Given this list of marker genes Cers3, Elovl1, Vapa, Fa2h, Acer2, Elovl2, Zfp750, Cerkl, Paqr4, Ormdl3, Hacd2 (NCBI Gene Id 70757), St6galnac3, St6galnac4, Elovl4, St8sia3, Abca2, Sgms1, Tm9sf2, St3gal2, St3gal1, Agk, P2rx1, Degs1l, Degs2, B4galnt1, Osbp, Samd8, Alox12b, Ugt8a, St8sia6, Tlcd3b, Hacd3, Acer3, Gzmb, B3galt4, Hacd1, B3galt1, Asah2, B4galt3, Fut9, Sptlc2, Cers4, Kdsr, St3gal3, Sphk2, St8sia2, Elovl7, Smpd4, St6galnac6, Sptlc1, Cers5, St8sia5, Pemt, Fut4, Pnpla1, Sgms2, P2rx7, Casp1, Elovl3, A3galt2, Cers1, B3galt2, Sirt3, Cers6, Mecr (mitochondrial trans-2-enoyl-CoA reductase), B3gnt5, Gal3st1, Casp7, Prkcd, Ormdl2, Enpp7, B4galt4, Atg7, Sptssb, Ccn1, Sptssa, Gba1 (NCBI Gene Id 14466), B4galt6, Ugcg, Ormdl1, Acer1, Elovl6, Asah1, Degs1, A4galt, Gm6993, Pla2g6, St6galnac1, 6430550D23Rik, Abca8a, Smpd5, Cers2, Sphk1, Abca8b (NCBI Gene Id 27404), Smpd1, Cyp4f39, Aloxe3, Smpd3, Sptlc3, St8sia4, Prf1, St6galnac5, Hacd4, Smpd2, B4galt5, Elovl5, Gsdmd, here is a description of the gene set: species: Mus musculus The chemical reactions and pathways resulting in the formation of sphingolipids, any of a class of lipids containing the long-chain amine diol sphingosine or a closely related base (a sphingoid). Mouse Gene Set: GOBP_SPHINGOLIPID_BIOSYNTHETIC_PROCESS